Given this list of marker genes TRMT10A (NCBI Gene Id 93587), FBXL19-AS1, SEPTIN9, NRIP3, UGT1A9, FAM234A, LRRC15, NDRG3, QSOX1, APOD (apolipoprotein D), KCTD11, PIGK, GSTT2, ANXA9, ALG14, STAU1, HMGCL, LDHC, TWF2, OXR1, VASN, GAPVD1, SUZ12, KIF21A, UQCRFS1, HIGD1A, STK3, CYB5R3, P2RY2, here is a description of the gene set: Transcriptional effects of estrogen result from its activation of two estrogen receptor (ER) isoforms; ERalpha that drives proliferation and ERbeta that is antiproliferative. Expression of ERbeta in xenograft tumors from the T47D breast cancer cell line reduces tumor growth and angiogenesis. If ERbeta can halt tumor growth, its introduction into cancers may be a novel therapeutic approach to the treatment of estrogen-responsive cancers. To assess the complete impact of ERbeta on transcription, we have made a full transcriptome analysis of ERalpha- and ERbeta-mediated gene regulation in T47D cell line with Tet-Off regulated ERbeta expression. Of the genes and transcripts analysed, 4.1% (1434) were altered by ERalpha activation. Tet withdrawal and subsequent ERbeta expression inhibited the ERalpha regulation of genes and, in addition, altered expression of 152 non-ERalpha-regulated genes. ERalpha-induced and ERbeta-repressed genes were involved in proliferation, steroid/xenobiotic metabolism and ion transport. The ERbeta repressive effect was further confirmed by proliferation assays, where ERbeta was shown to completely oppose the ERalpha-E2 induced proliferation. Additional analysis of ERbeta with a mutated DNA-binding domain revealed that this mutant, at least for a quantity of genes, antagonizes ERalpha even more strongly than ERbeta wt. From an examination of the genes regulated by ERalpha and ERbeta, we suggest that introduction of ERbeta may be an alternative therapeutic approach to the treatment of certain cancers. from publication Williams C, Edvardsson K, Lewandowski SA, Ström A, Gustafsson JA (PMID 17700529) species: Homo sapiens Genes uniquely up-regulated in T47D cells (breast cancer) by induction of ESR2 expression in the Tet-Off system. Human Gene Set: WILLIAMS_ESR2_TARGETS_UP